The following is a description of a gene set: Aplasia/Hypoplasia of the ulna Human Gene Set: HP_APLASIA_HYPOPLASIA_OF_THE_ULNA Absence or underdevelopment of the ulna. studied in species Homo sapiens, and this is the list of marker genes: FANCI, BMPR1B, EXOC6B, ESCO2, BRCA2 (BRCA2 DNA repair associated), GSC, CHD7, APC, LMBR1, CCDC8, JAG1, SCARF2, SF3B4, ERCC4, MAD2L2, PIGT, FANCL, RECQL4 (NCBI Gene Id 9401), FANCF, BRCA1, FANCM, COL2A1, DYNC2H1, RPL26, ROR2, FANCA, DHODH, OBSL1, PDE4D, RBM8A, FANCC, B2M, FANCE, TBX5 (NCBI Gene Id 6910), LRP4 (NCBI Gene Id 4038), VPS35L, WNT7A, SLX4, RFWD3, GDF5, XRCC2, NOG, CUL7, BRIP1, CHST3, FANCD2, RAD51C, PALB2, SALL4, RAD51, FANCB, IHH, FANCG, FGFR2, SHOX, PRKAR1A, UBE2T, FLNB (filamin B), TBX3, BHLHA9